Given this list of marker genes WASF1, CDC25B, SAMSN1, PELI1, CEBPD, STK26, SPATA7, CCL26, PDK4, APH1B, HS2ST1, ADAP2, TPD52L2, GLDN, FNBP1, H1-2, FAM91A1, ALS2, ARL8A, BLVRB, PSMG1, CEMIP2, RIC1, P2RY12, PREX1, RIMOC1, SETD2, SLC18B1, BASP1, FCHO2, ATF7, TBK1, AFF1, WDFY2, PMP22, OLFML2B, AP2A2, FCGR3B, FZD2, KLHL12, PAK2, CUL9, FCGR2A, CFAP97, CD180, JMJD1C, PITHD1 (PITH domain containing 1), SNTB2, RNF144B, PRKCE, FKBP5, PKN1, GATM, CIZ1, GGA2, RHOBTB3, TRIM32, ANKS1A, GTF2H1 (general transcription factor IIH subunit 1), SIGLEC1, TANGO2, SHMT1, SECTM1, SPRED1, ITPKC, SAP30, TSC22D3, SSH2, FOXN2, HRH1, CMKLR1, SPIDR, NAIF1, DIAPH2, ZNF395, OGDH, SNCA, THRAP3, SDC3, PLEKHA2, CLEC3B, SORBS3, SLC46A1, C9orf72, LARP4, PIP4P1, ABLIM3, RAB42, PIK3IP1, ETNK1, ETV5, GIMAP5, TMEM37, STARD13, FER, MYO7A, TNS1, FOXRED2, RBPJ, DAAM2, PIK3R5, MXD1, EPS15, GLMP, CSNK2A2, RHOBTB1, LZTS2, MLLT1, STAT5A, MPP1, STING1, C2, MYC, ENTR1, GCOM1, MTSS1, YPEL2, RASSF2, IFITM3, FLOT1, REPS2, SRPX, RBP1, FRAT1, TRIM14, PGBD1, MS4A6E, FRMD4B, QPRT, GRB2, TBC1D16, CCL23, ZNF787, ZBED1, CORO7, ACTRT3, FYB1, CCDC97, SELENOP, ARHGAP26, SNX9, JPT2, TSHZ1, ST8SIA4, SNX1, TLR5, DTX3L, ULK3 (unc-51 like kinase 3), RERE, TRIM37, KDM7A, PLS1, NUDT16, CNTLN, STAB1, SLC16A7, TLR2, H2AC25, RABGAP1, CNDP2, NCF4, TBC1D14, SSBP2, CEP128, ADAT2, TRIM28, TRPS1, HELZ, PDPK1, DPH6, LRRC58, LACC1, GBGT1, PFKM, MERTK, AHCY, SH3GL1, DENND11, RGL1, LILRB5, DIP2B, FILIP1L, ADORA3, POR, SERPING1, ABLIM2, MACROH2A1, SH3PXD2B, TRIM47, DUSP3, VSIG4, GCNT1, MKNK1, ITSN1, CRYL1, TFCP2L1, GID4, ARID5B, here is a description of the gene set: from publication Kwon H, Thierry-Mieg D, Thierry-Mieg J, Kim HP, Oh J, Tunyaplin C, Carotta S, Donovan CE, Goldman ML, Tailor P, Ozato K, Levy DE, Nutt SL, Calame K, Leonard WJ (PMID 20064451) Interleukin-21 (IL-21) is a pleiotropic cytokine that induces expression of transcription factor BLIMP1 (encoded by Prdm1), which regulates plasma cell differentiation and T cell homeostasis. We identified an IL-21 response element downstream of Prdm1 that binds the transcription factors STAT3 and IRF4, which are required for optimal Prdm1 expression. Genome-wide ChIP-Seq mapping of STAT3- and IRF4-binding sites showed that most regions with IL-21-induced STAT3 binding also bound IRF4 in vivo, and furthermore, revealed that the noncanonical TTCnnnTAA GAS motif critical in Prdm1 was broadly used for STAT3 binding. Comparing genome-wide expression array data to binding sites revealed that most IL-21-regulated genes were associated with combined STAT3-IRF4 sites rather than pure STAT3 sites. Correspondingly, ChIP-Seq analysis of Irf4_/_ T cells showed greatly diminished STAT3 binding after IL-21 treatment, and Irf4_/_ mice showed impaired IL- 21-induced Tfh cell differentiation in vivo. These results reveal broad cooperative gene regulation by STAT3 and IRF4. studied in species Homo sapiens Genes down-regulated in T cells treated with IL21: 6h versus 24h. Human Gene Set: GSE19198_6H_VS_24H_IL21_TREATED_TCELL_DN